Given this list of marker genes BICD2, EIF5A, TNPO3, XPO1, RANBP2, here is a description of the gene set: Human Gene Set: GOCC_ANNULATE_LAMELLAE species: Homo sapiens Stacks of endoplasmic reticulum (ER) membranes containing a high density of nuclear pores, thought to form from excess nuclear membrane components, that have been described in a number of different cells. Annulate lamellar membranes are continuous with and embedded within the ER.